The following is a description of a gene set: Human Gene Set: GOBP_POSITIVE_REGULATION_OF_NUCLEOBASE_CONTAINING_COMPOUND_TRANSPORT species: Homo sapiens Any process that activates or increases the frequency, rate or extent of the directed movement of nucleobases, nucleosides, nucleotides and nucleic acids, into, out of or within a cell, or between cells, by means of some agent such as a transporter or pore., and this is the list of marker genes: NCBP2, CPSF6, KHDRBS1, ADORA1, DHX9, NRDE2